The following is a description of a gene set: from publication Gargalovic PS, Imura M, Zhang B, Gharavi NM, Clark MJ, Pagnon J, Yang WP, He A, Truong A, Patel S, Nelson SF, Horvath S, Berliner JA, Kirchgessner TG, Lusis AJ (PMID 16912112) species: Homo sapiens Oxidized phospholipids are thought to promote atherogenesis by stimulating endothelial cells (ECs) to produce inflammatory cytokines, such as IL-8. In studies with mouse models, we previously demonstrated that genetic variation in inflammatory responses of endothelial cells to oxidized lipids contributes importantly to atherosclerosis susceptibility. We now show that similar variations occur in cultured aortic ECs derived from multiple heart transplant donors. These variations were stably maintained between passages and, thus, reflect either genetic or epigenetic regulatory differences. Expression array analysis of aortic EC cultures derived from 12 individuals revealed that >genes were regulated by oxidized phospholipids. We have used the observed variations in the sampled population to construct a gene coexpression network comprised of 15 modules of highly connected genes. We show that several identified modules are significantly enriched in genes for known pathways and confirm a module enriched for unfolded protein response (UPR) genes using siRNA and the UPR inducer tunicamycin. On the basis of the constructed network, we predicted that a gene of unknown function (MGC4504) present in the UPR module is a target for UPR transcriptional activator ATF4. Our data also indicate that IL-8 is present in the UPR module and is regulated, in part, by the UPR. We validate these by using siRNA. In conclusion, we show that interindividual variability can be used to group genes into pathways and predict gene-gene regulatory relationships, thus identifying targets potentially involved in susceptibility to common diseases such as atherosclerosis. Human Gene Set: GARGALOVIC_RESPONSE_TO_OXIDIZED_PHOSPHOLIPIDS_MAGENTA_UP Genes from the magenta module which are up-regulated in HAEC cells (primary aortic endothelium) after exposure to the oxidized 1-palmitoyl-2-arachidonyl-sn-3-glycerophosphorylcholine (oxPAPC)., and this is the list of marker genes: CSRNP1, LINC00622, BTN2A1, MAFG, PRDM4, NUP153-AS1, KIAA0232, TNPO1, BPGM, FBXO30, DNAJA1, PTP4A1, HSPA8, MAFF, RASD1, PTGS2, KANSL1L, KLF6, DUSP16 (NCBI Gene Id 80824), PPP1R15A, ZSWIM6, LATS2, ZNF844, GABARAPL1, FOSL2, RIT1, ABL2, HAPSTR1